Given this list of marker genes Rogdi, Perp, Amtn, Tcirg1, Relt, Stim1, Enam, Itgb6, Foxo1, Tgfb1, Klk4, Dicer1, Slc24a4, Fam20c, Dmp1, Ppara, Mmp20, Tbx1 (T-box 1), Odaph, Csf3r, Cftr, Nectin1, Ascl5, Cnnm4, Atf2, Slc4a2, Amelx, Dspp, Wdr72, Fam20a, Klk5, Msx2, here is a description of the gene set: Mouse Gene Set: GOBP_AMELOGENESIS The process whose specific outcome is the formation of tooth enamel, occurring in two stages: secretory stage and maturation stage. studied in species Mus musculus